The following is a description of a gene set: species: Mus musculus Reactome Pathway: Antigen processing: Ubiquitination & Proteasome degradation This event has been computationally inferred from an event that has been demonstrated in another species.<p>The inference is based on the homology mapping from PANTHER. Briefly, reactions for which all involved PhysicalEntities (in input, output and catalyst) have a mapped orthologue/paralogue (for complexes at least 75% of components must have a mapping) are inferred to the other species. electronically inferred by orthology from the curated human pathway part of: Class I MHC mediated antigen processing & presentation, and this is the list of marker genes: Fbxo40, Smurf1, Ccnf, Fbxl15, Ubb, Klhl5, Socs3, Kbtbd13, Cdc34, Psmd12, Trim11, Ube2e3, Ube2w, Cdc26, Psmb6 (proteasome (prosome, macropain) subunit, beta type 6), Fzr1, Rps27a, Fbxl8 (NCBI Gene Id 50788), Trim69, Det1, Rnf111, Glmn, Ubac1, Cul7, Fbxw9, Trim9, Psmd6, Psmb4, Ube2r2, Rnf6, Pja2, Psmc4, Thop1, Cul1, Uba7, Psmc3, Trim39, Trim32, Asb18 (ankyrin repeat and SOCS box-containing 18), Asb16, Ube2g1, Hectd3, Psma6, Fbxl19, Fbxl5, Lrr1, Fbxl13, Ube2c, Btbd6, Spsb2, Psma1, Siah1a, Klhl11, Ube2e2, Fbxo30, Anapc10, Asb17, Ube3c, Asb5, Psma2, Gan, Asb9, Tpp2, Herc3, Arel1, Cbll1, Asb11, Uba1, Btbd1, Vhl, Asb14, Fbxl14, Ube3d, Fbxo27, Lrsam1, Fbxl16, Asb8, Asb10, Psmc1, Anapc2, Cblb, Ube2d1, Fbxw4, Uba5, Pja1, Fbxl3, Psmd1, Rnf4, Dtx3l, Fbxo10, Psma5, Rnf19a, Rnf123, Fbxl21, Psmd7, Rnf217, Fbxo31 (NCBI Gene Id 76454), Dcaf1, Anapc7, Arih2, Psmd13, Traip, Ufl1 (NCBI Gene Id 67490), Psmc5, Ube2o, Fbxo17, Asb12, Kbtbd8, Prkn, Fbxo32, Psma3, Ube2v1, Psma7, Klhl13, Rnf126, Rnf213, Smurf2, Ube3b, Hecw2, Ube2s, Unkl, Socs1, Hectd2, Rnf144b, Rchy1, Fbxl7, Anapc13, Psmb7, Fbxl4, Psmc6, Trim36, Rnf7, Psma4, Fbxo9, Mib2, Psmc2, Ube2n, Wsb1, Ube2k, Psmb5, Lonrf1, Cdc23, Lnx1 (NCBI Gene Id 16924), Atg7, Klhl41, Lmo7, Kctd7, Kctd6, Rnf182, Ube2e1, Trim50